Given this list of marker genes SMOC2, HHIP, COL23A1, ZEB1, TSPAN2, GNPTAB, NOG, PDGFC, TACC2, PMEPA1, OCIAD2, HES6 (NCBI Gene Id 94875), DPP10, ITGA5, RIMS1, COL12A1, MYL4, CD24, FOXP4, NFATC1, SMTNL2, ALKAL1, PAQR4, IRAG1, ALKAL2, TNNI1, FENDRR, LRIG1 (leucine rich repeats and immunoglobulin like domains 1), BCL11A, CHCHD7, SYNPO2, TOX, HTRA1, KREMEN2, TES, CHRM3, LIMS2, ASB2, KCNMB1, CXCL14, NHSL3, CACNA1C, MPPED2, ACTG2, CORO1C, FOXP2, ARL4A, TRAF5, CSRP2, FHL2, NET1, AKAP1, PSAT1, CDH6, RAMP1, ISM1, GPR20 (NCBI Gene Id 2843), ANOS1 (NCBI Gene Id 3730), CEP120, IL17B, SLC25A4, SEMA3C, MIR99AHG, RASL11B, TNFRSF12A, CRTC1 (CREB regulated transcription coactivator 1), TSPAN18, SLMAP, IGFBP2, MYOCD, ADAMTS6, CNN1, ATP2A3, PRKAG2, C3orf70, SORBS1, RALGPS2, B3GALNT2, ADAM19, RBM38, FBXL22, CARMN, ITGA11, MIR503HG, FST, KRT8, PDLIM4, WFDC1, SCD, ATL2, MSRB3, KLF7, RHCG, IGF1, CAP2, GBP2, HHIP-AS1, CDC42EP3, LINC00472, TMEM59L, FBN3, FHDC1, CAVIN2 (caveolae associated protein 2), MTCL1, TNNT2, KIF26B, SPOCK3, ALDH1B1, CLSTN2, HMGA2, SSC5D, NRG2, LMOD1, ENC1, TYRP1, GREM2, JPH2, NKD1, SPSB1, MYH11, TUBB2B, SPEG, ADAMTSL2, SBSPON, here is a description of the gene set: MYL4+ SMC Human Gene Set: HE_LIM_SUN_FETAL_LUNG_C0_MYL4_POS_SMC_CELL studied in species Homo sapiens from publication He P, Lim K, Sun D, Pett JP, Jeng Q, Polanski K, Dong Z, Bolt L, Richardson L, Mamanova L, Dabrowska M, Wilbrey-Clark A, Madissoon E, Tuong ZK, Dann E, Suo C, Goh I, Yoshida M, Nikolić MZ, Janes SM, He X, Barker RA, Teichmann SA, Marioni JC, Meyer KB, Rawlins EL (PMID 36493756)